The following is a description of a gene set: from publication Matzuk MM, Lamb DJ (PMID 18989307) species: Mus musculus Reproduction is required for the survival of all mammalian species, and thousands of essential 'sex' genes are conserved through evolution. Basic research helps to define these genes and the mechanisms responsible for the development, function and regulation of the male and female reproductive systems. However, many infertile couples continue to be labeled with the diagnosis of idiopathic infertility or given descriptive diagnoses that do not provide a cause for their defect. For other individuals with a known etiology, effective cures are lacking, although their infertility is often bypassed with assisted reproductive technologies (ART), some accompanied by safety or ethical concerns. Certainly, progress in the field of reproduction has been realized in the twenty-first century with advances in the understanding of the regulation of fertility, with the production of over 400 mutant mouse models with a reproductive phenotype and with the promise of regenerative gonadal stem cells. Indeed, the past six years have witnessed a virtual explosion in the identification of gene mutations or polymorphisms that cause or are linked to human infertility. Translation of these findings to the clinic remains slow, however, as do new methods to diagnose and treat infertile couples. Additionally, new approaches to contraception remain elusive. Nevertheless, the basic and clinical advances in the understanding of the molecular controls of reproduction are impressive and will ultimately improve patient care. Mouse Gene Set: MATZUK_SPERMATOZOA Spermatozoa genes, based on mouse models with male reproductive defects., and this is the list of marker genes: Nphp1, Pcsk4, Bbs2 (Bardet-Biedl syndrome 2), Nsun7, Brdt, Adcy10, Aff4, Zpbp2, Lrp8, Polg, Gapdhs, Tgfb1, Pold4, Sh2b1, Spag16, Rxrb, Tekt4, B4galt1, Cplx1, Clgn, Hspa4l, Pebp1, Gmcl1 (germ cell-less, spermatogenesis associated 1), Spag9 (sperm associated antigen 9), Gba2, Pacrg, Pgs1 (NCBI Gene Id 74451), Cadm1, Acr, Tnp1, Pgap1, Mthfr, Smpd1, Strbp, Crem, Adamts2, Spam1, Prkar1a, Camk4, Bbs1, Adcy3, Slc12a2, Gamt, Nipa1, Ros1 (NCBI Gene Id 19886), Adad1, Vdac3, Bbs4, Cga, Cib1, Taf7l (NCBI Gene Id 74469), Spem1, Egr4, Rhox5, Akap4, Ahr, Spmap2, Mmel1, Sirt1, Plcb1, Cnot7, Adam2, Cd81, Prnd, Prm2, Prm1, Selenop, Jam3, Septin4, Atp2b4, Dnah1, Prkaca (protein kinase, cAMP dependent, catalytic, alpha), Bub1, Apob, Tnp2, Zpbp, Csnk2a2, Cfap221, Spag6, Ldhc, Hook1, Agfg1, Klhl10, Cenpb, Rasip1, Rbmxl2, Fhl5, Tcf21, Rxfp1 (NCBI Gene Id 387561), Tsn, Inpp5b, Pltp, Plcd4, Piwil1, Slc9c1, Cd59b (CD59b antigen), Cstf2t, Taldo1, Arl4a, Jund, Tssk6, Vipr2, Wipf3, Nectin2, Smcp, Adam3, Agtpbp1, Ace, Tekt3, Tekt2, Gopc, Pla2g4c, Fndc3a, Gdi1, Mfge8 (NCBI Gene Id 17304)